The following is a description of a gene set: studied in species Mus musculus Binding to a ganglioside, a ceramide oligosaccharide carrying in addition to other sugar residues, one or more sialic acid residues. Mouse Gene Set: GOMF_GANGLIOSIDE_BINDING, and this is the list of marker genes: Rtn4r, Mag, Psap, Epdr1, Clip3